Given this list of marker genes Hpcal4, Bsnd, Stx8, Micu3, Lrrc55, Grm2, Kcnmb1 (NCBI Gene Id 16533), Grm3 (glutamate receptor, metabotropic 3), Lrrc38, Gpd1l, Fxyd5, Atp1b1, Stx1a (syntaxin 1A (brain)), Tmprss3, Stom, Amigo1, Phpt1, Hamp, Kcnmb2, Calm3, Tmem168, Kcng1, Cabp1, Cacng8, Kcnip4, Agt, Cacng7, Kcne4, Ank2, Stoml1, Cftr, Fxyd2, Trpv1, Snf8, Arpp19, Prss8, Abcc9, Cabp5, Cacng1, Sumo1, Calm1, Cnih2, Atp2b4, Wnk3, Nrxn1, Kcns2, Snca, Tspan13, Kcnab3, Cav3, Lrrc52, Kcng4, Nedd4, Kcne3, Adrb2, Kcne5, Prkg1, Micu2, Kcnk2, Kcng2, Calm2, Fgf12, Kcns1, Cacng4, Pacsin3, Fgf11, Rrad, Hamp2, Slc15a1, Glrx, Wnk4, Lamp2, Kcne2, Crisp4, Ano9, Fxyd1, Gpld1, Nedd4l, Ywhah, Kcnv1, Prkcz, Kcnb2, Gem, Prss30, Kcnmb4, Sgk3, Scn3b, Kcne1, Rasa3, Actb, Scn1b, Ensa, Pdzd11, Slc30a1, Cacng6, Cacng3, Cacnb3, Fxyd7, Fxyd4, Smdt1, Scn2b (NCBI Gene Id 72821), Itpr1, Kcng3, Cabp4, Atp1b3, Pcsk9, Lrg1, Akap9, Sclt1, Cd44, Vti1b, Scn4b, Lynx1, Pias3, Nrxn2, Cav1, Camk2d, Lamp1, Dpp6, Tnni3, Snta1, Rem2, Kcnip1, Atp6ap1, Commd1, Kcns3, Kcnip2, Gnb2, Kcnip3, Atp1b2, Dlg1, Fkbp1b, Flna, Nos1, Wnk2, Tmc7, Prkcb, Vamp8, Cacng2, Nherf1, Cacnb2, Sgk2, Fxyd6, Stim2, Grm7, Micu1, Slc5a3, Stx7, Kcnv2, Wnk1, Ptpn3, Fgf14, Ywhae (tyrosine 3-monooxygenase/tryptophan 5-monooxygenase activation protein, epsilon polypeptide), Cacng5, Dpp10, Chrna7, Kcnab1, Kcnb1, Stimate, Sgk1, Lrrc26, Rem1, Fxyd3, Rangrf, Fkbp1a, Kcnmb3, Rack1, Nrxn3, Bcl2, Fgf13, Pde4d, Cnih3, Cabp2, Mcub, Kcnf1, Clcn2, Stim1, Akt1, Kcnab2, here is a description of the gene set: Mouse Gene Set: GOMF_TRANSPORTER_REGULATOR_ACTIVITY Binds to and modulates the activity of a transporter. studied in species Mus musculus